Given this list of marker genes Ins1, Rgn, Erfe, Pfkfb1, Foxk2, Adipoq, Rora, Arpp19, Stk11, Ppp1r3e, Tigar, Ep300, Slc25a12, Adora2b, Sirt1 (sirtuin 1), Nln, C1qtnf12, Actn3, Ppp1r3b, Kat2a, Obp2a, Gnmt, Mup5 (NCBI Gene Id 17844), Akt1, Hnf4a, Oprm1, Ppp1r3g (NCBI Gene Id 76487), Serpina12, C1qtnf3, Zfp692, Mup1, Pth, Ppp4r3a, Adcy10, Ppp1ca, Mst1, Phkg1, Sirt7, Ogt, Mir143, Prkag1, Prkag2, Bckdk, Sorbs1, Nr3c1, Akt2, Gck, Ptpn2, Ins2, Pgp, Cry1, Slc35b4, Dyrk2, Ppp4r3b, Hmgb1, Sirt6, Irs2, Mup2, Gnb3, Insr, Ranbp2, Phkg2, Foxk1, Gcg, Igfbp4, Lcmt1, Gpld1, Usp7, Pdk4, Prkaca, Cyp2j6, Sik1, Pmaip1, Adipor1, Tcf7l2, C1qtnf2, Trp53, Hif1a, Esrrb, Dgat2, Sesn2, Ppara, Lepr, Acacb, Dgkq, Il6, Lep, Xpc, Clk2, Fbp1, Acadm, Pdk1, Slc45a3, Mup4, Pdk3 (pyruvate dehydrogenase kinase, isoenzyme 3), Tff3, Irs1, Ncoa2, Mup11, Foxo1, Zmpste24, C1qtnf1 (NCBI Gene Id 72004), Rorc, Pdk2, Phkb, Adra1b, Ddb1, Igf2, Mup3, Epm2aip1, Src, Phka1, Kat2b, Prkag3, Nfe2l1, Igfbp3, Mtcl2, Nkx1-1, Gpt, Wdr5, Fgl1, Mlycd, Supt20, Igf1, Nnmt, here is a description of the gene set: Any process that modulates the rate, frequency or extent of glucose metabolism. Glucose metabolic processes are the chemical reactions and pathways involving glucose, the aldohexose gluco-hexose. studied in species Mus musculus Mouse Gene Set: GOBP_REGULATION_OF_GLUCOSE_METABOLIC_PROCESS